Given this list of marker genes GPR83, CXCR3, TNFRSF18, IL10 (interleukin 10), RGS2, JUN, IZUMO1R, CREM, DLK1, DDX5, SLAMF7, CCR7, CCR2, FOS, PAK1, SOCS2, ITGAE, ADGRE5, MECP2, GZMB, PDCD1LG2, CCR5, GADD45B, here is a description of the gene set: Naturally arising CD25+CD4+ regulatory T cells (T(R) cells) are engaged in the maintenance of immunological self-tolerance and immune homeostasis by suppressing aberrant or excessive immune responses, such as autoimmune disease and allergy. T(R) cells specifically express the transcription factor Foxp3, a key regulator of T(R)-cell development and function. Ectopic expression of Foxp3 in conventional T cells is indeed sufficient to confer suppressive activity, repress the production of cytokines such as interleukin-2 (IL-2) and interferon-gamma (IFN-gamma), and upregulate T(R)-cell-associated molecules such as CD25, cytotoxic T-lymphocyte-associated antigen-4, and glucocorticoid-induced TNF-receptor-family-related protein. However, the method by which Foxp3 controls these molecular events has yet to be explained. Here we show that the transcription factor AML1 (acute myeloid leukaemia 1)/Runx1 (Runt-related transcription factor 1), which is crucially required for normal haematopoiesis including thymic T-cell development, activates IL-2 and IFN-gamma gene expression in conventional CD4+ T cells through binding to their respective promoters. In natural T(R) cells, Foxp3 interacts physically with AML1. Several lines of evidence support a model in which the interaction suppresses IL-2 and IFN-gamma production, upregulates T(R)-cell-associated molecules, and exerts suppressive activity. This transcriptional control of T(R)-cell function by an interaction between Foxp3 and AML1 can be exploited to control physiological and pathological T-cell-mediated immune responses. Human Gene Set: ONO_FOXP3_TARGETS_UP studied in species Mus musculus from publication Ono M, Yaguchi H, Ohkura N, Kitabayashi I, Nagamura Y, Nomura T, Miyachi Y, Tsukada T, Sakaguchi S (PMID 17377532) Genes up-regulated in CD4+ T lymphocytes transduced with FOXP3.